Given this list of marker genes VSTM2A, NR1H2, SCARB1, ZC3H12A, HILPDA, PLIN2, APOB, MSR1, C3, EHD1, MIR34A, IKBKE, ACACB, LPL, PLIN5, MIR144, MIR10B, NFKB1, APOC4, SREBF2, PLIN3, CD36 (NCBI Gene Id 948), PLA2G10, here is a description of the gene set: studied in species Homo sapiens Any process that increases the rate, frequency or extent of lipid storage. Lipid storage is the accumulation and maintenance in cells or tissues of lipids, compounds soluble in organic solvents but insoluble or sparingly soluble in aqueous solvents. Lipid reserves can be accumulated during early developmental stages for mobilization and utilization at later stages of development. Human Gene Set: GOBP_POSITIVE_REGULATION_OF_LIPID_STORAGE